The following is a description of a gene set: Mouse Gene Set: REACTOME_AZATHIOPRINE_ADME Azathioprine ADME species: Mus musculus, and this is the list of marker genes: Impdh2, Abcc5, Tpmt, Gsta3, Gsta1, Vav2, Abcc4, Impdh1, Nme2, Rac1, Slc28a2 (NCBI Gene Id 99455), Nudt15, Gmps, Guk1, Gstm2, Vav1, Xdh, Gsta5, Slc29a2, Gsta2, Gsta13, Hprt1, Nme1, Slc28a3, Slc29a1, Vav3